Given this list of marker genes UROS, UROD, EPM2A, NHLRC1, GATA1, DHCR7, here is a description of the gene set: A severe degree of photosensitivity of the skin. species: Homo sapiens Human Gene Set: HP_SEVERE_PHOTOSENSITIVITY Severe photosensitivity